Given this list of marker genes Tomm6, Tomm5, Ube2n, Atg12, Prkn, Tomm7, Map1lc3b (NCBI Gene Id 67443), Mterf3, Ube2v1, Optn, Ubb, Vdac1, Sqstm1, Vdac2, Tomm20, Rps27a, Mfn2, Tomm22, Vdac3 (NCBI Gene Id 22335), Pink1, here is a description of the gene set: part of: Mitophagy electronically inferred by orthology from the curated human pathway Reactome Pathway: PINK1-PRKN Mediated Mitophagy studied in species Mus musculus This event has been computationally inferred from an event that has been demonstrated in another species.<p>The inference is based on the homology mapping from PANTHER. Briefly, reactions for which all involved PhysicalEntities (in input, output and catalyst) have a mapped orthologue/paralogue (for complexes at least 75% of components must have a mapping) are inferred to the other species.